The following is a description of a gene set: Genes having at least one occurrence of the motif GATTTAACATAA in the regions spanning 4 kb centered on their transcription starting sites. This matches the CDC5L transcription factor binding site V$CDC5_01 (v7.4 TRANSFAC). studied in species Homo sapiens Human Gene Set: CDC5_01, and this is the list of marker genes: SLC27A4, FYN, PIK3R3, RRH, GOLPH3L, RGS1 (NCBI Gene Id 5996), NPVF, HOXC6, PIK3R1, SESN3 (NCBI Gene Id 143686), RCOR1, PPP2R2B, PBX1 (PBX homeobox 1), MSX1, NKX2-3, CPNE1, KLHL4, NRP1 (neuropilin 1), ATOH1, GJA3, TSHZ2, HOXC12, TLE1, C1orf21, ARHGAP44, HOXD12, RASAL2, TMSB4X, MGLL, ELP3, ADAMTS6, ZNF516-DT, HESX1, EYA1, RORA, EGR2 (NCBI Gene Id 1959), PDGFA, DIP2B, PBX2, TAFA1, EDRF1, SNTG1, KCTD15, BMPR2, IL21, MTTP, DNAJC5B, DLL4, HRK, BTBD3, SALL1, HIVEP3, CACNA1C, NOL4, SLC44A5, LRFN5, ACTR10, PRRX1, PROK2, WDR27, MYH6 (NCBI Gene Id 4624), HOXC5, CADM1, MYL2, PABIR3, SALL3, MBNL1, HMGA1, ALX1, NSMCE3, ARRDC3, INPP4B, OSER1, TMSB4XP4, TGIF1, FUT11, FAM53C, PURA, PTBP3, HOXA11, PLEKHH3, PABIR1, SUPT16H, STAT3, DNASE1L2, PRPS1, CDH6, ENPP2, CPEB4, ATRX, ESRRG, CALD1, KLF8, EMILIN1, CHRNA5, TCF21, VANGL1, ZNF827, POU3F1, ZFPM2, ODF1, RARA, IL20, BCL6, TNNI3K, MAML1, FOXP1, SEC63, SLCO2A1, UNC13D, FOXP2, COL16A1, PDZRN4, NPTX1, LRR1, MUSK, FGF10, LYN, PRKACB, EMC4, CDKN2C, AP1S2, CCL20, RREB1, USP13 (ubiquitin specific peptidase 13), ADAMTS9, SHH, AICDA, XIAP, HOXA9, SMTNL2, BAMBI, FOXA1, ABLIM1, CREB5, SREK1, HOXD9, RBMS1, BCL11B, CUTA, GPR85, PHOX2B, YWHAG, SLITRK2, POT1, ANGPT1, RBM26, NLK, RPA2, TMSB4XP8, ZBTB20, CTNND1, CDC42EP3, MINK1, STAG2, ARPC5L, TMSB4XP6 (TMSB4X pseudogene 6), FBXL19-AS1, MOS, SCN7A, MN1, SCUBE3, LMO3, KLHL32, DUSP14, PSMA8, GMCL2, ERRFI1, TNNI1, HOXD10, OSR2, CLDN1, BCOR, GFRA1, TRPS1, PCDH8, ACSL4, TGFB3, BMAL1, SMARCA2, NDRG4, CHD2, TMSB4XP1, SCP2D1, CITED2, CDIN1, KLF4, PCDHGC3, HOXB7, FRMD4A, FGF12, H3-3B, GPC3, POGLUT1, KCNK12, HMGB4, ARMCX4, SYT4, SAT1 (NCBI Gene Id 6303), PHF21A, FNBP1, HAO2, EDA, UCHL1, HIPK1, MPLKIP, PLAG1, INO80B, NKX2-1, PLCB3, CTTNBP2NL, DLG2, ITPKB, FES, GLI3, MXI1, ADGRB3, GPR87, B3GNT6, TNFSF10, GK, LMNA, KLF12, TMSB4Y, TENM1, VSTM2L, SOBP (sine oculis binding protein homolog), SAMSN1, TNS2, ING3, CUX1, CENPI, PRKAG1, NREP, CHRDL1, CSNK1G3, DGKB, ACSM6, C12orf42, OTP, SGK3, SDC1, NRXN3, PPARGC1A (NCBI Gene Id 10891), WBP1L, NAP1L5, VDR, PAX2, VEGFA, HSPA2, SLC6A13, FOXN3, NEK6, RORB, PRDM13, NOVA1, LIN7A, NRAS, TMPRSS3, LINC00670, HNRNPA0, CLASP1, MYL1, BACH2, IL25, SLC12A8